Given this list of marker genes Calm2, Pde1a, Gngt2, Drd4 (NCBI Gene Id 13491), S1pr2, Bdkrb2, Rgs9, Gna15, Ackr3, Sstr5, Gna11, Ccl25, Ccr4, Prkacb, Ccr9 (C-C motif chemokine receptor 9), Chrm4, Tas1r1, Psap, Grm3, Npbwr1, Galr3 (galanin receptor 3), Cxcr5, Gpsm1, Prkcd, Tas2r119, Agt, Gnb3, Cx3cr1 (NCBI Gene Id 13051), Galr2, Npy, Plcb2, Ccl19, Grk2, Grm8, Rgs20, Gpr55, Galr1, Adcy3, Ccr7, Cxcl16, Pmch, Tas2r137, Ccl27a, Ccl21d, Gngt1, Gpsm3, Rgs7, Apln, Ptger3, Adcy2, Grm2, Ppp1r1b, Gng2, Prkar1b (protein kinase, cAMP dependent regulatory, type I beta), Npb, Prkar1a, Plcb3, P2ry4, Rgs6, Cnr1 (NCBI Gene Id 12801), Sstr2, Sucnr1, S1pr3, Gng12, Gpr37, Pyy, Aplnr, Prkaca, C3, Sstr4, C3ar1, Ccl6, Ccl5, Cdk5, Gabbr1, Gal, Ccl21b, Mtnr1b, Gnat3, Tas2r130, Tas2r144, Gnai1, Gnb2, Cxcl13, Gna14, Ppp2ca, Pde1c, Cnr2, Lpar5, Ccl1, Cort, Pde4a, Rgs21, Gpr17, Adora1, Rgs16, Rgs19, Npy1r, Pf4, Adra2c, Tas1r3, Gnb4, Cxcl12, Cxcr2, Rgs11, S1pr4, Rgs18, Rrh, Gnat2, Insl5, Rgs13, Gng8, Opn5, Kng2, Cxcr3, Pomc, Pde1b, Grm6, Anxa1, Gpsm2, Ccl21e, Gnai3, Pcp2, Cxcl10, Rgs17, Calm3, Nmur1, Gnb1, Grm7, Rho, Lpar2 (lysophosphatidic acid receptor 2), Tas2r138, Htr1d, Drd3, Tas2r139, Casr, Cxcr6, Nmur2, Ccl28, Fpr-rs4 (formyl peptide receptor, related sequence 4), Plcb4, Htr5a, Oprk1, Oprl1, Npy5r, Gpr31b, Oprd1, Hcar2, Ccr10, Oxgr1, Cx3cl1, Pde4b, Ccl20, Fpr2, Plcb1, Adcy1, Rgs5, Rln3, Adra2a, Adora3, Fpr-rs7, Rgs1, Cxcl3, Rxfp3, Gng4, Cxcl5, Rxfp4, Agtr2, Lpar3, Ppp2r1a, Opn3, Ccr8, Mtnr1a, Htr1f, Gng7, P2ry12, Ccl11, Ppp2r5d, Pla2g4a, Hcar1, Camkk1, Nmu, Pde4d, Ppp2r1b, P2ry13, Adcy5, Tas2r121, Ccl4, Chrm2, Cxcr1, Tas2r118, Ccl27b, Ccl21f, Gnat1, Gnb5, Gng11, Ccl27al, Tas2r120, Opn1mw, Calm1, Hrh4, Tas2r135, Gng5, Pde4c, Ptgdr2, Sst, Gpr37l1, Gper1, Ccr6, Ccr1, Ppbp, Gabbr2, Camkk2, Npw, Gnai2, Lpar1, Ccr3, Mapk1, Src, Tas2r136, S1pr5, Adcy7, Npy2r, Fpr3, Cxcr4, Gnaq, Penk, Tas2r126, Ppp1ca, Gpr18, App, Cxcl9, Cxcl11, Gng10, Hebp1, Pnoc, Gng3, Opn1sw, Rgs12, Tas2r131, Rgs3, Ccr5, Cxcl2, Oprm1, Adcy8, Adcy6, Ccl21a, Rgs4, Fpr-rs6, Gpr183, Gng13, Tas2r140, Pdyn (NCBI Gene Id 18610), Htr1b, Sstr1, Cxcl1, Nms, Gnal, Rgr, Ppp2cb, Grm4, Prkcg, Tas2r108, Bdkrb1, Tas1r2, Hc, Fpr1, P2ry14, Ccl9, Fpr-rs3, Adcy9, Ppy, Adcy4, Mchr1, Adra2b, Sstr3, Npy4r, Rgs8, C5ar1, Tas2r106, Rgs14, here is a description of the gene set: Mouse Gene Set: REACTOME_G_ALPHA_I_SIGNALLING_EVENTS studied in species Mus musculus G alpha (i) signalling events